Given this list of marker genes Gm13479, 6330409D20Rik, Or1u1-ps1, Or1n2, Endog, Or1ao1-ps1, Gm25264, Or1j9-ps1, Gm13414, Lrsam1, Ncs1, Aif1l, Gm13496, Gm13451, Mir6336, Psmd5, 9330198N18Rik, Mir1954, Gm14488, Pdcl (NCBI Gene Id 99318), Gtdc1, Rbm18, Or1j16, Or1j4, Stxbp1, Nup214, Dnm1, Prrx2, Or12k8, Snord90, Or1l4b, Or12k5, Mir3960, Gapvd1, Or1n1, St6galnac6, Or1j13, 4930527E20Rik, Gm13610, Gm13523, Mir5129, Gm13588, Rab14, Gm22516, Niban2 (NCBI Gene Id 227737), Or1j1, Fibcd1, Gm13400, Coq4, Zbtb34, 9030204H09Rik, Fubp3, Nup188 (nucleoporin 188), Zeb2os, Lhx6, Gm13446, Mrrf, Slc2a8, Gm13529, Plpp7 (phospholipid phosphatase 7 (inactive)), Mir219b, Hc, Cdk9, Golga1, Crat, Gm24165, Pkn3, Gm13465, Gm35808, Gm13524, Scai, Gm14486, Eeig1, Gm13450, Naif1, Mir181b-2, Ier5l, 4930568D16Rik, Nek6, Psmb7 (NCBI Gene Id 19177), Mir8093, Cfap157, Fnbp1, Or12k6-ps1, Asb6, Lrp1b, Setx, Zbtb43, Or1ak2, Ralgps1, Mir3154, Zeb2, Glo1-ps, 9430097D07Rik, Tbc1d13 (TBC1 domain family, member 13), Wdr38, Spout1, Gm13430, Adgrd2-ps, 5730507A11Rik, Gm13586, Ciz1, Rabgap1, Gm13426 (NCBI Gene Id 100416172), Arhgap15os, Rapgef1, Rc3h2, Strbp, Ndufa8, Prrt1b, Stom, Gm13506, Ttll11 (tubulin tyrosine ligase-like family, member 11), Vmn2r-ps2, Nr5a1, Phf19, Gm13461, Tor1b, 6530402F18Rik, Gm24467, Gm13456 (NCBI Gene Id 666531), Or1j21, Or1j22-ps1, Gm26236, Gm16523, Mapkap1, Or1af1, Gm13609, BC005624, Or12k7, Gm13611, Gm13474 (NCBI Gene Id 630799), Phyhd1, Gm18791, Gm23546, 9430024E24Rik, Dolpp1, Tor1a, Or1l8, Mir5128, Lamc3, Mir199b, Abl1, Miga2 (mitoguardin 2), Gm13427, Ptrh1, Or1j8, Gm13408, Or1j10, Or1j17, Gm13477, Gm13449, Swi5, Gm13543, Or1j18, Traf1, Gm13605, Kynu, Gm13478, Gm13452, Mir219a-2, Or1n1b, Gpr107, Zdhhc12, Fpgs, Dync2i2, Mir3089, Ass1, Dolk, Slc27a4, Ptges2, 4930402F06Rik, Mir181a-2, Gm13536, Lrrc8a, Rpl35, Trub2, Gm13431, Dab2ip, Mir133c, Gm13608, Gm13469, Hspa5, Bbln, Gm13436, Or1l4, Gm13403, Fbxw2, AI182371, Gm13406, Gm13470 (NCBI Gene Id 102633065), Set, 1700084E18Rik, B3galt9 (beta-1,3-galactosyltransferase 9), Uck1, Gm13404, Gm13435, Prrc2b, Gm13428, Lcn2, Cutal, Gm13466, Exosc2, Or1j12, Ptges (prostaglandin E synthase), Lmx1b, Gm14487, Sh2d3c (SH2 domain containing 3C), Nr5a1os, Gm23072, Gm13454, Or1j19, Prdm12, Mir7674, Or5c1, Tor2a, Mir6997, Med27, Gm13445, Qrfp, C79798, Olfr363-ps, Gpr21, Crb2 (crumbs family member 2), Zbtb26, Gm13482, Gm13462, Gm35202, Dennd1a, C230014O12Rik, Arpc5l, Or1q1, Gm13528, Urm1, Ak1, Nr6a1os, Rpl12, Angptl2, Rabepk, Mir2861, Morn5, Dpm2, Gm13444, Golga2, Gm13437, Gm28643, Garnl3, Zbtb6, Gm10829, Gsn, Gle1, Ntng2, Lhx2, Gm23369, Eng, Ptgs1, Pip5kl1, Or1j20, Slc39a1-ps, Or1j11, Gm13530, Gm13407, Mvb12b, Pbx3, Fam78a, St6galnac4, Or1j15, C130021I20Rik, Or1b1, Snora65, D330023K18Rik, Ptpa, Gm13429, Gm25081, Usp20, Nr6a1, Or1j14, Nron, Sh3glb2, Cntrl, Gm24905, Or7c74, Cercam, Gm13584, Gm17893, Gm28035, 2600006K01Rik, Ttc16, Ntmt1, Gm13425, Kyat1, 1700001O22Rik, Gm13547, Ppp6c, Gm13453, Sptan1, Gm13458, Slc25a25 (NCBI Gene Id 68663), Rpl15-ps4, Cstad, Zer1, Arhgap15, Pomt1, Odf2, Mir6998, Ggta1, Gm13464, Btf3-ps9, Olfml2a, Hmcn2, Gm13413, Or1v1-ps1, here is a description of the gene set: studied in species Mus musculus Mouse Gene Set: chr2B